The following is a description of a gene set: studied in species Homo sapiens Human Gene Set: GOBP_PHOTORECEPTOR_CELL_MORPHOGENESIS The process in which the structures of a photoreceptor cell are generated and organized. This process occurs while the initially relatively unspecialized cell is acquiring the specialized features of a photoreceptor cell, a sensory cell that reacts to the presence of light. An example of this is found in Drosophila melanogaster., and this is the list of marker genes: MFSD2A, CDHR1 (NCBI Gene Id 94000), CFAP418, BBS1, CABP4